The following is a description of a gene set: Human Gene Set: GOBP_REGULATION_OF_BONE_MINERALIZATION_INVOLVED_IN_BONE_MATURATION species: Homo sapiens Any process that modulates the frequency, rate or extent of bone mineralization involved in bone maturation., and this is the list of marker genes: RFLNA, LTF, BMP2, GREM1, PTH, RFLNB, ACTN3